Given this list of marker genes ALG3, here is a description of the gene set: Reactome Pathway: Defective ALG3 causes CDG-1d studied in species Homo sapiens Dol-P-Man:Man(5)GlcNAc(2)-PP-Dol alpha-1,3-mannosyltransferase (ALG3) adds the sixth mannose (although the first to be derived from dolichyl-phosphate-mannose, DOLPman) to the lipid-linked oligosaccharide (LLO) intermediate GlcNAc(2) Man(5) (PPDol)1. Defects in ALG3 are associated with congenital disorder of glycosylation 1d (ALG3-CDG, CDG1d; MIM:601110), a multisystem disorder caused by a defect in glycoprotein biosynthesis and characterised by under-glycosylated serum glycoproteins. CDG type 1 diseases result in a wide variety of clinical features, such as defects in the nervous system development, psychomotor retardation, dysmorphic features, hypotonia, coagulation disorders, and immunodeficiency. part of: Diseases associated with N-glycosylation of proteins